The following is a description of a gene set: studied in species Homo sapiens Genes predicted to be targets of miRBase v22 microRNA hsa-miR-612 in miRDB v6.0 with MirTarget v4 prediction scores > 80 (high confidence targets). Human Gene Set: MIR612 from publication Chen Y, Wang X (PMID 31504780), and this is the list of marker genes: CXXC4, ABCB8, RC3H1, HOXA13, LRRC31, NF2, SMAD6, CRTC1, CKAP4, LARP1, LRRC41, YAP1, NUDT19, PRR14L, COL4A5, SIKE1, IFT122, TMEM41B, PTGES3L, CCNT1, ZBTB8B, NRP1, FMOD, ACP6, RAB11FIP3, TANGO2, FOXP4, APPBP2 (amyloid beta precursor protein binding protein 2), CMTR2, NDOR1, TPI1, SRR, RYBP, SIDT1, NECTIN1, IPO9, GPI, DAB2IP, NUFIP2, SEC63, TMEM127, JRK, CMKLR1, TRMT13, ARF6, KCNK2, AHI1, YTHDF1, FGF14, NXF1, GPR62, PPP2R2B, RBMS2 (RNA binding motif single stranded interacting protein 2), MDGA1, GDNF (glial cell derived neurotrophic factor), FAM120C, ARRDC3, SPRTN, ATP8A1, PLOD1, GABRA1, CHL1, RD3, PHF21A, NLRP14, PRND, HIVEP3, TRABD2B, BTRC, C1orf210, SSH2, LRRTM3, ZNHIT6, DCTN5, AKAP13, RARB, APBB2, SEC14L1, ARNT2, SLC25A12, PPP3CB, PTEN, PSD3, SRFBP1, KDM2B, SMPD1, SAR1A, TFAP2A, CEACAM7, KCNB1, RMI1, TCTN3, CCP110, DDX11, FBXO33, GIPC3, FMO5, CREB5, FOXP1, ZNF322, PLEKHM1, MARCKSL1